The following is a description of a gene set: part of: G2/M Transition Reactome Pathway: Centrosome maturation studied in species Mus musculus This event has been computationally inferred from an event that has been demonstrated in another species.<p>The inference is based on the homology mapping from PANTHER. Briefly, reactions for which all involved PhysicalEntities (in input, output and catalyst) have a mapped orthologue/paralogue (for complexes at least 75% of components must have a mapping) are inferred to the other species. electronically inferred by orthology from the curated human pathway, and this is the list of marker genes: Tuba1a, Cep41, Cep290, Csnk1e, Tuba4a, Cdk11b, Mzt1, Haus5, Dynll1, Nde1, Sfi1, Cep131, Tubgcp3, Tubb4a (NCBI Gene Id 22153), Plk1, Cep135, Cep152, Dctn1, Prkaca, Cenpj, Cdk1, Tubgcp2, Ywhae, Ninl, Cep192, Prkar2b, Haus8, Tubgcp6, Haus1, Cep72, Cep43, Nedd1, Clasp1, Cep57, Haus7, Cep63, Sdccag8, Actr1a, Tubb4b